Given this list of marker genes CCNH, POLR2L, ERCC2, 45S pre-rRNA gene, POLR1H, GTF2H5, TBP, KAT2B, GATAD2A, RRN3, CDK7, POLR1G, EHMT2, POLR2F, POLR1D, POLR2E, GATAD2B, POLR1F, POLR2K, POLR1B, GTF2H1, MNAT1, GTF2H4, CHD4, TAF1D, GTF2H2, UBTF, MBD3, HDAC1, GTF2H3, POLR1C, POLR2H, POLR1E, ERCC3 (ERCC excision repair 3, TFIIH core complex helicase subunit), RBBP7, TAF1A, CHD3, RBBP4, KAT2A, TAF1C, TAF1B, MTA2, HDAC2, POLR1A, MTA1, TTF1, ERCC6, MTA3, here is a description of the gene set: During initiation the double-stranded DNA must be melted and transcription begins. SL1 forms and interacts with UBF-1 and the rDNA promoter. It is this platform that will recruit active RNA polymerase I to the SL1:phosphorlated UBF-1:rDNA promoter complex.<p>Mammalian rRNA genes are preceded by a terminator element that is recognized by the SL1 complex. This SL1 modulated acetylation of the basal Pol I transcription machinery has functional consequences suggesting that the reversible acetylation may be one way to regulate rDNA transcription. part of: RNA Polymerase I Promoter Clearance Reactome Pathway: RNA Polymerase I Transcription Initiation studied in species Homo sapiens